The following is a description of a gene set: species: Homo sapiens Human Gene Set: GOBP_POSITIVE_REGULATION_OF_BONE_MINERALIZATION Any process that activates or increases the frequency, rate or extent of bone mineralization., and this is the list of marker genes: GPM6B, ISG15, MEF2C, ACTN3, PTH, RXRB, RXRA, ADRB2, ATP2B1, ATRAID, P2RX7, PTN, BMPR1A, BMP6, TFAP2A, BMPR1B, WNT4, SLC8A1, CCN1, NELL1, WNT10B, FAM20C, OSR2, BMP7, BMPR2, KL, TENT5A, FZD9, BMP2, SLC20A2, ACVR2A, ADGRV1, TMEM119, ACVR1, LTF, OSR1, ACVR2B, FBN2, BMP4 (bone morphogenetic protein 4), ANO6, PKDCC, VDR, ALOX5, SMAD3